Given this list of marker genes Grn, Apoh, Slamf8, Rps19, Dusp10, Ins1, Bcr, Ins2, here is a description of the gene set: Any process that decreases the rate frequency or extent of a phase of elevated metabolic activity, during which oxygen consumption increases; this leads to the production, by an NADH dependent system, of hydrogen peroxide (H2O2), superoxide anions and hydroxyl radicals. Mouse Gene Set: GOBP_NEGATIVE_REGULATION_OF_RESPIRATORY_BURST species: Mus musculus